The following is a description of a gene set: from publication Chen Y, Wang X (PMID 31504780) Human Gene Set: MIR625_3P Genes predicted to be targets of miRBase v22 microRNA hsa-miR-625-3p in miRDB v6.0 with MirTarget v4 prediction scores > 80 (high confidence targets). studied in species Homo sapiens, and this is the list of marker genes: ADGRF5, POLR1F, PAPOLA, ZBTB34, SLC24A1, PRICKLE2 (NCBI Gene Id 166336), MANEA, GALNT1, SLC34A2, NDUFAF5, ARID1A, PTPN12, DNAJA1, EZH2, ERBIN, APOL6, NEUROD1 (neuronal differentiation 1), C11orf87, CPEB4, PIP5K1B, ARF6, MAP3K1, RBM27, COMMD8, ASIC5, PDP1 (NCBI Gene Id 5497), DNAJA2, FLG2, PTPRD, BBOF1, NADK2, KDM7A, WDR76, MAB21L2 (NCBI Gene Id 10586), SP8, CCDC126, SOCS5, GNL3L, IL5RA, TNFSF11, THRAP3, SLC39A10, GPC6, NUP37, ALAS1, PYGO1, LEPROTL1 (leptin receptor overlapping transcript like 1), ODAPH, USP42, ZFPM2, FAM151B